The following is a description of a gene set: Mouse Gene Set: GOBP_REGULATION_OF_TRANSPORT Any process that modulates the frequency, rate or extent of the directed movement of substances (such as macromolecules, small molecules, ions) into, out of or within a cell, or between cells, by means of some agent such as a transporter or pore. studied in species Mus musculus, and this is the list of marker genes: Lypd10, Chp1 (NCBI Gene Id 80510), Sri, Itsn1, Prrt1 (NCBI Gene Id 27693), Cryab, Pla2g10, Anp32b, Mapk14, Zic1, Tspan18, Golph3l, Spg7, Rala, Rbp4, Acvr1c, Lipg, Prkca (protein kinase C, alpha), Prl2c5, Cd63, Tmem14a, Cep131, Cplx4, Cdh13, Sox4, Apoa2, Ptprv, Ptch1, Sv2c, Epo, Atp9a, Zfas1, Trpm4, Rab25, Ifnb1, Kcnj9, Sdcbp, Ang6, Abcb11, Wnk3, Use1, Hyal3, Drd4, Lpar3, Appl1, Kalrn, Trim27, Ice1, P2rx1, Unc13a, C1qtnf2, Cd200, Ndufaf2, Mlc1, Trpm5, Stxbp4, Prpf4b, Clasp1, Xbp1, Pltp, Sod1 (superoxide dismutase 1, soluble), Appl2, Kcna2 (NCBI Gene Id 16490), Cxcl10, Oprd1, Cx3cl1, Sorl1, Gfap, Uhmk1, Inha, Sftpd, Stom, Smad4, Cnih3, Dynll1, Pnkd, Sh3gl3, Bcap31, Dhrs7c, Scrn1, Lgals3, Calr, Psen1, Ahcyl1, Akt3, Acsl3, Mef2c, Ddx39a, Mir410, Sh3glb1, Unc13b, Peg12, Ighg1, Tert, Rangrf, Tm7sf3, Jak2 (NCBI Gene Id 98155), Umod, Ppp3ca, Ighm, Lcp1, Rgcc, Khdrbs1, Rac1, Nr1d1, Thy1, Stxbp3, Plscr1, Negr1, Mcub, Fgfr1 (fibroblast growth factor receptor 1), Hgs, Pln, Yjefn3, Bin1, Rgs9, Apoc2, Hes1, Ndfip1, Jagn1, Gip, Rgs2, Tlr4, Trpm2, Cyp27b1, Dnaja1, Rapgef4 (Rap guanine nucleotide exchange factor (GEF) 4), Sstr4, Dync1h1, Cdh2, Hrh3 (NCBI Gene Id 99296), Corin, Jak3, Mtnr1a, Ntrk2, Abl1, Atg3 (NCBI Gene Id 67841), Stx1a, Ggcx, Gpr143, Cd81, Gsk3a, Rab4b, Sox11, Snapin, Nppc, Ldlrap1, Stx4a, Mtmr4, Tmem38a, Myo5a, Nnat, Fgg, Fpr-rs7, Cacng7 (NCBI Gene Id 81904), Derl3, Lbp, Ehd4, Iscu, Pfkm, Ston1, Selenon, Akap6, Reep6, Rabep1, Ptprn, Cpb2, Rnf216, Lypd11, Sirt2, Pim3 (NCBI Gene Id 50885), Myo5b, Os9, Mbtps1, Esr1, Ank2, Slc25a22, Prl3d3, Pram1, Nrde2, Fzd9, Clasp2, Snap23, Eif3e, Tmem97, Pfkfb2, Pros1, Fgb, Madd, Bves, Serp1, Nlgn3, Hmga2, Tbc1d1, Derl2, Cpsf6, Akt1, Cacnb3, Tbc1d5, Numa1, Alkbh5, Slc18a1, Ndel1, Ndfip2, Dpysl2, Grin2d, Cacnb4, Cebpb, Snx12, Abca7, Midn, Ccl21a, Trim28, Znrf2, Ctnnb1, Phb2, Rap1gds1, Edem1, Gpc3, Casr, Nkx2-5, Ces1h, Bmp4, Lilra5, Crebl2, Acaa2, Sstr5, Avpr1b, Trf, Rhbdd1, Tnfrsf1a, Exph5, Abca2, Cdh1, Lrrc26, Cacnb2, Tm9sf4, Ces1e, Tifab, Abca8b, Prl2c1, Hbp1, Mir130a, Frat2, Edn2, Sidt2, Pdpk1, Bdkrb1 (NCBI Gene Id 12061), Trpv3, Rab7, Kel, Cnst, Sar1a, Vegfc, Pdgfrb, Nherf1, Nedd4l, Sergef, Aacs, Sirt4 (sirtuin 4), Calm2, Apoa4, Cyp4a10, Brsk2, Nr1h4, Mdfic, Arv1, Ildr1, Mylk, Wnk2, Bmp2, Grik1, Cd151, F2rl1, Kiss1, Srebf2, Adora1, Ehd3, Bicd1, Cacng8, Pdgfb (platelet derived growth factor, B polypeptide), Nedd4, Camk1, Mmp9, Abca1, Adcy8, Fgf12, Nutf2-ps1, Mfn2, Trpc6, Bglap2, Sec24b (NCBI Gene Id 99683), Zc3h12a (zinc finger CCCH type containing 12A), Sybu, Atad1, Ppp3cc, Notch1, Pacsin2, Acsl5, Atp8a2, Pcsk1, Tgm2, Atp2c2, Erlec1 (endoplasmic reticulum lectin 1), Slc10a4, Ppm1f, Nkx6-1, Nrg1, Prap1, Rab5a, Vdac1, Stx1b, Ep300, Tub, Il16, Sh3tc2, Hip1, Slc25a31, Syt6, Kiss1r, Tunar, Cers1, Hsd3b2, Cacna1a, Dcx, Tcf7l2, Kcnab1, Or51e2, Epm2a, Atp2b1, Slc11a1, Nup214, Gli3, Fgf23, Trdn (triadin), Eppin, Ucn3, Add1, Fis1, Pea15a, Vps4a, Rdx, Mical1, Itgb3, Mtmr2, Slc38a1, G6pd2, Vsnl1, 1810037I17Rik, Pik3r2, Il11 (NCBI Gene Id 16156), Sco1, Ghrhr, Npsr1, Cryaa, Mapt, Ppp3r1, Cbll1, Kcnn2, Chchd4, Cd47, Ppid, Mlxipl, Cdk5, Shh, Uqcc2, Abca3, Lmx1b, Rab11fip5, Cldn19, Edn3, Stxbp1, Htr6, Zp3, Shank1, Cdk1, Lrat (NCBI Gene Id 99631), Lpar1, Ccr1l1, Nipsnap2, Ehd1, Pard3, Clec7a, Cdkn2a, Baiap3, Gstm7, Sh3gl2, Rims3, Jph4, Clock, Dock2, Ldc1, Aoc3, Tac1, Riok2, Rhbdd3, Kif5b, Aimp1, Drd1, Lif, Cln3, Mup11, Bcr, Syngr3, Git2, Gab2, C3, Gjc2, Syn1, Rin3, Actn2, Necab2, Vegfa, Kcnc4, Pon1, Fxyd1, Ptk2, Ctss, Siglecf, Gopc, Il12b, Cela2a (chymotrypsin-like elastase family, member 2A), Fga, Kcnc2, Adipoq, Slc26a6, Rnf220, Nup58, Ace, Spx, Ei24, Arg2, Bglap, Rab27a, Pde4d, Akap5, Hsp90ab1, Hnrnpk, S100a9, Pot1b, Adora2b, Lrrk2, Hspa8, Klf7, Rapgef3, Mup1, Triap1, Nefh, Fgr, Kcnj8, Tmem168, Kcnj15, Egfr, Ttn, Egf, Sphk1, Pacsin1, Ptpn11, Flot1, C1qtnf1, Hnf4a, Cd38, Grm2, Cacna1i, Casp3, Rhot1, Kif3a, Rap1a, Slc31a2, P2rx2, Dnajc6, Capn10 (NCBI Gene Id 98655), Rap1gap, Bax, Gcg, Srcin1, Scn5a, Cldn10, Ptpmt1, Gata2, Ffar3 (NCBI Gene Id 233080), Stxbp5l, Cckar, Cacna1h, Cd74, Gnaz, Smo, Bsn, Prkcd, Cldn3, Dmpk, Commd1, G6pdx, Tnk2, Cplane2, Atp4b, Syt2, Creb1, Ano6, Cd14, Fto, Epn2, Maob, Cd19, Wnk4, Prkci, Epha5, Slc30a1, Tpr, Ttc39d (NCBI Gene Id 67737), Adam9, Ric1, Lrp1, Ubr5, Usp2, Lyar, Prkar1b, Per2, Tmem132a, Atf4, Selenot, Atp1b1, Uaca, Pick1, Bsg, Cav3, Btk, Pclo, Itln1 (NCBI Gene Id 640587), Cacng4 (calcium channel, voltage-dependent, gamma subunit 4), Trib3, Dnm2, Shisa9, Ghrh, Lime1, Ptpn3, Gnao1, Cd300lf, Osbpl6, Abr, Oaz1, Kcne3, Pomc, Syt3, Cckbr, Tulp1, Pcnt, Sh3gl1, Vtn, Plcg2, Kcnj13, Ankrd1, Hck, Rhoq, Mink1, Snca, Prelid1, Kcnip2, Blk, Acsl1, Cnr1, Bok, Hap1, Cdk16, Ipo5, Epb41l1, Nfkb1, Gpr35, Arhgap21, Nr1h3, Apbb1, Prl, Ces1a (NCBI Gene Id 244595), Htr1d, Anxa1, Apela, Ubash3b, Tbc1d4, Prkcq, Fkbp1b (NCBI Gene Id 14226), Tpcn2, Smpd3, Efcab7, Ptafr, Itgb1 (integrin beta 1 (fibronectin receptor beta)), Runx1, Vamp1, Synj2bp, Jsrp1, Rufy3, Abca8a, F2rl3, Ednra, Chmp2a, Tenm1, Anxa5, Dbn1, Plk2, Ms4a2, Rims1, Il2rg, Slc17a8, Neu3, Fxyd5, Ahnak, Ppard, App, Ahr, Cartpt, Gbp4, Rest, Kcne1, Ccl2, Scfd1, Tff2, Ezr, Ppp1cc, P2rx7, Foxl2 (forkhead box L2), Slc6a4, Map4k4, Pllp, Pou4f2, Efhb, Coro1a, Atp2b2, Yes1, Braf, Nup153, Rasa1, Nsf, Ccl5, Rasgrf1, Prl2c3, Kcne5, Trpv2, Thoc2, Atp4a, Clec4b1, Fpr-rs3, Lhcgr, Hrc, Dbi, Vamp8, Npff, Kcnk9 (potassium channel, subfamily K, member 9), Abcb4, Abcb1b, Abcg4, Rab8a, Adora2a, Scn2b, Erc2, Il15 (NCBI Gene Id 16168), Alox5, Tspo, Camk4, Ptges, Rab21, Lep, Ace2, Ighg2b, Xpo4, Ager, Cxcr3, Fcgr2b, Cacna2d1, Slc12a2, Chd7, Irak1, Mmp13, Cntn1, Grin2b, Lrp2, Cox17, Rspo1, Stap1, Shisa7, Nlrp6, Abca13, Bak1, Pdx1, Mtnr1b, Sln, Car7, Pink1, Trem2, Ffar2, Dvl1, Mertk, Piwil4, Cnksr3, Rab15, Tspan13, Fgf21, Il1a, Nfe2l2, Rock1, Ankrd13b, Washc1, Fabp3, Slc2a2, Pdcd5-ps, Chmp3, Sv2a, Tmbim6, Hnrnpm, Ywhab, Pid1, Spg11, Mpv17l, Abca12, Pde1c, Ghsr, Syt8, Il6, Nkx3-1, Tmem184a, Cdh3, Slc17a7, Glp1r (NCBI Gene Id 14652), Bet1l, Slc30a3, Kcnq1, Susd4, Homer1, Wipf1, Il13, Cblb, Dnajc1, Gh, Actb, Sfrp1, Dll1, Atg5, A1cf, Afg3l2, Snph, Drd2, Syt10 (NCBI Gene Id 54526), Sirt3, Ptger3, Nat8l, Wfdc6a, Chrna4, Creb3, Bpifa1, Nkain2, Vac14, Ripk1, Crbn, Tlr9 (NCBI Gene Id 81897), Lgi3, Gipr, Crh, Rem1, Myb, P2rx5, Fasl, Bard1, Prl3b1, Ubqln2, Grk2, Syt9, Sphk2, Ffar1, B3gat3, Npy1r, Plpp4, Tmc2, Kcnj2, Gata1, Doc2g, Slc35d3, Rab8b, Myt1, Slc35f6, Crhr1, Bad, Rps6kb1, Slc16a1, Serpine2, Plcd1, Rab31, Best3, D6Wsu163e, Gsk3b (NCBI Gene Id 98033), Dlg4, Cacna1b, Trim58, Pycard, Nol3, Vps28, Chrna3, Ncdn, Avp, Nr0b2, Prl6a1, Rtn4, Cplx2, Frat1, Slc43a2, Mff (mitochondrial fission factor), Snap91, C2cd5, Aak1, Slc18a2, Zfand1, Cyp51, Rab11fip1, Lyplal1, Slc9a6, Sdc4 (syndecan 4), Atp2b4, Tnnc1, Wfs1 (NCBI Gene Id 22393), Fpr-rs4 (formyl peptide receptor, related sequence 4), Tmed10, Arhgef11, Ano1 (anoctamin 1, calcium activated chloride channel), Cttnbp2nl, Dennd10, Rimbp2, Ccr7 (NCBI Gene Id 12775), Ndrg4, Pth, Grem1, Atp13a2, Kcnn4, Pfkl (phosphofructokinase, liver, B-type), Prl3c1, Pla2g5, Angpt1, Slc25a27, Abcb1a, Erfe, Slc9b2, Gas6, Surf4, Hmgcr, Yod1, Plaa, Stac2, Trh, Fes, Psen2, Kdm5b, Rfx6, Efnb2, Mllt6, Micu3, Gnb5, Gria1, Map1lc3b, Pik3c2a, Inpp4b, Epha3, Ahsg, Arhgef5, Fxyd2, Gm14461, Arfgap1, Pck2, Ms4a1, Cd4, Catsper1, Dhx9, Nr1h2, Csk, Prl8a8, Prl7d1, Ran, Ier3, Dgkd, Znrf1, Cnih2, Scarb1, Ecrg4, Pik3cg, Slc26a5, Rapgef1, Rab37, Nherf2, Slc38a2, Slc9a3, Ppp1r9a, Prl8a6, Syt4, Tgfb1, Rab5c, Arfip1, Ifng, Ppp3cb, Rbm10, Pcp4, Pla2g3, Axl, Atxn2, Plp1, Cry2, Gripap1, Prtn3, Kcng4, Kctd7, Sytl4, Apoc3 (NCBI Gene Id 11814), Nfatc3, Fev, Akap8l, Itgb2l, Chchd10, Scg5 (secretogranin V), Wdr41, Ghrl, Retn, Dnajc5, Ncbp2, Stx18, Cacnb1, Nf1, Cxcl11, Smpd1, Myo18a, Prl4a1, Hsd3b3, Tmem30a, Neto1, Fcgr1, Cacng1, Tnfsf11, Ccn3, Kcnf1, Ccr2 (C-C motif chemokine receptor 2), Sirt7, Iqsec1, Tescl, Fgf10, Hamp2, Clcf1, Nus1, Cldn16, Atp2a2, Prl7b1, Eipr1, Lamtor1, Kcnab2, Stac3, Mex3b, Plk3, F2, Gcc2, Chrm1, Map1b, Letmd1, Prl5a1, Snx3, Azin1, C9orf72 (C9orf72, member of C9orf72-SMCR8 complex), Mcu, Mapk3, Il12a, Ccdc32, Eny2, Apln, Prss8 (serine protease 8 (prostasin)), Scn1b, Ptpn14, Vip, Snx4, Tspan7, Gal, Stk39 (serine/threonine kinase 39), Rfx3, Ocln, Cemip, Rab2b, Myo6, Gabbr1, Mup4, Jup, Rnf207, Psmd9, Ttc21b, Hsp90aa1, Ceacam1, Erc1, Dapk1, Ppia, Il4, Cacna1f, Itgav, Kcnh1, Fgfr4 (fibroblast growth factor receptor 4), Cbl, Cadps, Fgf13, Xcl1, Gramd2a, Foxf1, G6pc2, Pde8b, P3h1, Krt20, Tacr2, Mavs, Myom1, Cry1, Ankfy1, Lrrc52, Crhbp, Arpc3, Snf8, Arc, Lrrc55, Arf6, Sec24a, Kcnj11, Ifi27, Tek, Sfn, Fyn, Tmem102 (NCBI Gene Id 380705), Oxt, Fgf15, Lyset, Grik5, Syt15, Cask, Nmu, Rac2, Aqp2, Nell2, Pde4c, Tmem53, Apbb3 (amyloid beta precursor protein binding family B member 3), Slc36a2, Map2k6, Map2, Pawr, Fabp5 (fatty acid binding protein 5, epidermal), Ccl19, Pip5k1c, Wdr54, Nlgn1, Npy5r, C1qtnf12, Sdc1, Agt, Ucn2, Doc2b, Gnai2, Sik1, Mrln, Sumo1, Sec16b, Gpr27, Gnaq, Grm6, Mif, Nos1, Casq2, Cacna1c, Scrib, Kcnj3 (NCBI Gene Id 16519), Lypla1, Acsl4, Cacng6, Arhgef7, Wls, Ap1g1, Rit2, Fpr2, Cplx3, Spink1, Stk11, Ank3, Ptpn22, Strit1, Fmr1, Hmgn3, Tcaf1, Nf2, Ppfia2, Atp1a1, Grin3b, Mapk1, Rint1, Chga, Fcer1a, Bcl2, Dync1li1, Scn4b, Hcar2 (NCBI Gene Id 80885), Aqp1, Rab27b, Car2, Ndufa4 (Ndufa4, mitochondrial complex associated), Inpp5f, Mapk9, Glul, Tesc, Il1rn, Vps35, Reln, Cd177, Clu, Ptger4, Kcnj1, F2rl2, Pdcd6ip, Orai1, Fam3d, Gpr158, Rubcn, Tbc1d20, Mchr1, Kcnab3, Smap1, Chp2, Prkar1a, Ica1, Lrpap1, Tnfrsf1b, Il2rb, Ufm1 (ubiquitin-fold modifier 1), Tsg101 (tumor susceptibility gene 101), Rab33b, Repin1 (NCBI Gene Id 58887), Kcns2, Stim2, Malrd1, Uts2, Prepl, Dnajc13, Cplx1, Adtrp, Snap25, Pla2g4e, Oprm1, Erbb3, Dennd5b, Arhgap8, Nr4a3, Reep1, Sct, Inhbb, Arg1, Best1, Kcng1, Apoa1, Opn3, Fcrl5, Ptpn5, Mdm2, Ttc39b, Atp5if1, Prkd1, Il1rapl1, Spp1, Scn3b, Hpca, Prkce, Msn, Akt2, Hif1a, Efna5, Prl2b1, Pirt, Klf15, Cxcr4, Slc7a11, Reep2, P2ry4, Trpc4, Akap7, Tsc2, Gnb2, Alox12b, Ywhaq, Smim43, Prl3a1, Hk2, Ywhah, P2ry1, Pdcd5, Cep290, Prl7a1, Emd, Dmd, Pax8, Slc43a1, Hdac3, Srebf1, Idh2, Rab34, Prkcz (NCBI Gene Id 97193), Nckap1l, Tcp11, Siva1, Hmox1, Ica1l, Ffar4, Acvr2a, Apoc2l, Xrcc4, Pparg, Cyp19a1, Pdzk1, Cnn2, Cd84, Npr3, Hcrt, Grp, Htr7, Casq1, Alms1, Furin, Rgs4, Ehd2, Rims2, Cftr, Mup5, Grin2a (glutamate receptor, ionotropic, NMDA2A (epsilon 1)), Kcne2, Kcnip1 (NCBI Gene Id 72952), Rnf139, Slc6a1, Pou5f1, Dph3, Upk3b (uroplakin 3B), Pde3b, Ston2, Vps18, Igf1, Mapk8ip2, Trpc3, P2rx4, Cdk5r1, Stc1, Ptgs1, Ccl12, Pofut2, Tmed10-ps, Slc18a3, Galr1, F2r, Cbarp, Septin1, Map2k1, Trpa1, Septin5, Abcc9, Homer3, Dynlt2b, Dpp10, Kcng3, Lyn, Prkaa1, Slc15a1, Aplnr, Hfe, Cd300a, Rnasel, Pxk, Slc30a6, Scp2, Gpr151, Ap2b1, Tgfb2, Kcnmb1, Kcnc1, Nkain1 (NCBI Gene Id 72746), C2cd2l, Slc8a1, Edn1, Dmap1, Vamp3, Stc2, Gclc, Ccr1, Cyba, Lamp1, Iws1, Cd22, Arf1, Hip1r, Kcnj14, Gas1, Isl1, Prl2a1, Prkcg, Septin4, Ppm1a, Cacng2, Prkcb, Atp1b2, Zdhhc2, Cyp4a32, Smcr8, Fxyd6, Slc25a4, Golph3, Dysf, Rph3a, Vps11, Kcns1, Ube2j1, Sncg, Trim9, Brca1 (NCBI Gene Id 12189), Actn4, Pim1, Prkn, Septin8, Syt12, Arhgap1, Gper1, Cyp4a31, Doc2a, Tmx1, Ripor1, Lman2, Chrm3, Snap29, Gimap3, Cxadr, Cadps2, Lrrc8a, Usp46, Prr5l, Oprk1, Hspa2, Tprg1l, Prl8a9, Rcvrn, Adcyap1r1, Pik3r1, Cacng5, Tomt, Flna, Fcer1g, Arrb1, Zdhhc8, Chrnb2, S100a8, Vamp2, Cdc42, Pla2r1, Pkig, Rbm22, Slc1a2 (solute carrier family 1 (glial high affinity glutamate transporter), member 2), Nfkbia, Fgf14, Akap9, Sorbs1, Glud1, Htt, Osm, Dab2, Abcc8, Osbpl8, Nadk, Ankrd13d, Irs1, Rph3al, Myc, Ccl3, Sptbn4, Kcnj16, Ces1g (carboxylesterase 1G), Sv2b, Ntsr1, Syt11, Itpr1, Mecp2, Sgip1, Dnm3, Mctp2, Tmf1, Siglece, Thbs1, Ptpn23, C1qtnf3, Prkaca, Scamp5, Ankrd13a, Serpine1, Gnai1, Svip, Gdnf, Mapk8, Pcm1, Sar1b, Mpc2, Stimate, Lepr, Kcnh2, Park7, Nod2, Tacr1, Camk2a, Kif20b, Mib1, Ier3ip1, Hamp, Pex5l, Gja5, Arhgap44, Mbl1, Cyfip1, Azin2, Ubac2, Capn3, Arhgdia, Nppa, Hadh, Txn1, Unc13d, Acsl6, Oaz3, Atp7a, Numb, Yipf5, Apoc1, Rhbdf2, Tfr2, Kmo, Caly, Dnm1l, Cyp2j5, Neurog1, Syt17, Magi2, Aspscr1, Fbn1, Unc119, Ang4, Rab11fip3, Ptx3, Slc8b1, Bmp2k, Dgkq, Gsg1l, Hsd3b6, Enpp1, Tlr2, Wnk1, Erbb4, Rab5b, Dlg1, Slamf1, Ptprj, Fcnb, Cspg5, Birc5, Agtr2, Bag3, Cd160, Gpd1l, Rab3d, Cck, Ppt1 (palmitoyl-protein thioesterase 1), Adra2a, Hm629797, Myh10, Snx9, Nutf2, Pfn2, Picalm, Cntf, B2m, Prl2c2, Ros1, Sh2b2, Kcnj6, Calm1, Pcsk9, Asic2, Sirt1, Slc7a5, Trpc1, Prom2, Abcg1, Sytl2, Hmgb1, Saraf, Cldn2, Hyal2, Dkk1, Ang2, Crhr2, Npy, Dnm1, Stxbp5, Jph3, Mup2, Prrt2, Sestd1, Tgfb3, Wdr44, Kcnb1, Napb, Jph2, Plcg1, Borcs5, Kcnip4, Taco1, Tnf, Naxe, Inhba, Ankrd27, Sfrp4, Kcnj5, Gpr39, Mef2a, Asph (NCBI Gene Id 97379), Camk2n1, Apod, Pip4p2, Prl7a2 (prolactin family 7, subfamily a, member 2), Nucb2, Pard6a, Fbxo11, Hnf1a, Epb41, Gps2, Trim46, Tiam1, Grm7, Eprs1, Rhoa, Thoc5, Zpr1, Osbp, Wnt5a, Arap1, Pla2g6, Nrxn1, Atp2c1, Rabgef1, Bmp6, Rsad2, Cacna1e, Il1b, Synj1, Calm3, Vamp4, Rab23, Spag5, Apoe, Nkain4, Setd2, Btbd9, Atp8a1, Eef2k, Ins2, Rptor, Wnt7a, Fez1, Itgam, Fbxo45, Selenok, Cav1, Slc25a5, Neo1, Prl3d1, Tnnt2, Ngf, Kcnc3, Foxa2, Fkbp1a, Itga2, Arrb2, Akap1, Tardbp, Ap2a1 (NCBI Gene Id 11771), Ophn1, Prkg2, Slc4a8, Rufy4, Adrb1, Ces1b, Sgk1, Stam, Tor1a, Grin2c, Heph, Rap1b, Cwh43, Gpm6b, Erp29, Smim6, Irs2, Insr, Lrrc38 (NCBI Gene Id 242735), Tamalin, Mbl2, Fcgr3, Htr2a, Sele, P2ry12 (purinergic receptor P2Y, G-protein coupled 12), Ucn, Nlgn2, Gimap5, Pkdcc, Dtnbp1, Lrrtm2 (NCBI Gene Id 107065), Yrdc, Lrsam1, Fxyd3, Entpd1, Src, Stim1, Insig1, Atp1a2, Pld2, Slc30a8, Rbm4, Abat, Supt6, Ppp3r2, Prl8a2, Snta1, Vdr, Ergic3, Ptprc, Kcnj4, Rasgrf2, Oaz2, Chrna7, Syt5, Xpo1, Atpsckmt, Atp1b3, Kcnj10, Nr3c2, Ctdspl2, Septin2, Spi1, Arl6ip1, Rgs7, Gdf9, Cabp1, Cdk5r2, Syt13, Slc9a1, Rab11a, Fxyd7, Ren1, Camk1d, Ncoa6, Ppp1r12a, Idua, Il15ra, P2ry6, Ces1f, Pls3, Htr2c, Ptbp1, Exoc4, Ucp2, Pkia (protein kinase inhibitor, alpha), Oxct1, Alox15, Adipor2, Cacng3, Atp8b1, Oxsr1, Nos3, Ak1, Cracr2a, Igfbp3, Tnfrsf11a, Rab3a, Map2k2, Lpcat3, Avpr1a, H1f1, S100a10, Lrp5, Camk2d, Fhl1, Wnt3a, Ahi1, Galr2, Rims4, Myh9, Adcyap1, Rasl10b, Ywhae, Vmp1, Mir200a, Nr3c1, Arl6ip5, Nmb, Htr1b, Npvf, Amigo1, Lcn2, Gsto1, Nolc1, Prl3d2, Il4ra (NCBI Gene Id 16190), Agtr1a, Tcirg1, Itgb2 (integrin beta 2), Grb10, Pask, Ada, Hcls1, Anxa7, Acacb, Tmem30b, Fermt1 (fermitin family member 1), Il13ra2, Snx33, Cd36, Stxbp2, Prl7c1, Stac, Scn10a, Rab3c, Vps4b (NCBI Gene Id 319619), Atp2a1, Bcl2l1, Anxa2, Mettl21c, Colec11, Ntf3, Cacna1g, Pkd2, Slc34a1, Wwp2, Mylk2, Mul1, Tac4, Amph, Syt7, Tfap2b, Chrna6, Mctp1, Oga, Ptk2b, Dspp, Rufy1, Adrb2, Ces1c, Rab29, Cltrn (collectrin, amino acid transport regulator), Nkain3, Actg1, Gja1 (gap junction protein, alpha 1), Slc38a3, Wasl, Kcna5, Fxyd4, Fndc1, Cxcl1, Ptpn6, Adora3, Edem2, Sp100, Plcb4, Rab3gap1, Ckap5, Sftpa1, Lgals9, Tmc1, Rab26, Pla2g4a, Prkg1, Npy2r, Prl8a1, Sirt6, Ptgs2, Cpt1a, Homer2, Diaph1, Tmem38b, Ang5, Tmem74, Rack1, Pml, Pacsin3, Mtor, Rtn2, Dpp6, Rab11b, Rab3b, Trat1, Cd2ap, Clip3, Usp7, Ncs1, Pdcd10, Ppif, Cacna1d, Coa8, Ins1, Mup3 (major urinary protein 3), Cd209b, Bpifa5, Ostn, Cxcl12, Pld1, Prnp, Cxcl9, Ensa, Ap2m1, Colec10, Nsun2, Slc51b, Osr1, Exoc2, Sirpb1a, Asic1, Ang (NCBI Gene Id 11727), Rhbdf1 (rhomboid 5 homolog 1), Rab4a, Nos2, Fpr-rs6, Met, Oxtr, Ikbkb, Kcnip3, Plcb1, P2ry2, Gpld1, Gapvd1, Bmal1, Rab9, Sdhd, Slmap, Pgap1, Gpr68, Gprc6a, Ush1g, Ptprn2, Abca5, Git1, Rangap1, Lrrtm1, Ube2g2, Sirpa, Hrh2, Dctn1, Grin1, Frmd4a, Icam1, Syk, Agrn, Tspoap1, Fam76b, Gck, Myrip, Inpp5k, Ect2, Gna11, Nup62, Zbed6, Fbxl20, Per1, Ubqln1 (ubiquilin 1), Mkln1, Oas2, Zfp13 (zinc finger protein 13), Kcnj12, Hcfc1, Adcy5, Kcnrg, Pten, Foxo1, Ryr2, Atg7, Syt1, C2, Atp5pf, Grm8, Ces1d, Pgrmc1, Ubr3, Nup54, Gnas, Sncaip, Zfp384, Cfp, Htr1a, Drd3, Ptpn1, Scnn1b, Calhm1, Eepd1